The following is a description of a gene set: studied in species Mus musculus Genes up-regulated after 10 h of TGFB1 stimulation in MEF cells (embryonic fibroblast) with NFIC knockout vs wild type MEFs. Human Gene Set: PLASARI_TGFB1_SIGNALING_VIA_NFIC_10HR_UP Transforming growth factor beta (TGF-beta) and platelet-derived growth factor A (PDGFAlpha) play a central role in tissue morphogenesis and repair, but their interplay remain poorly understood. The nuclear factor I C (NFI-C) transcription factor has been implicated in TGF-beta signaling, extracellular matrix deposition, and skin appendage pathologies, but a potential role in skin morphogenesis or healing had not been assessed. To evaluate this possibility, we performed a global gene expression analysis in NFI-C(-/-) and wild-type embryonic primary murine fibroblasts. This indicated that NFI-C acts mostly to repress gene expression in response to TGF-beta1. Misregulated genes were prominently overrepresented by regulators of connective tissue inflammation and repair. In vivo skin healing revealed a faster inflammatory stage and wound closure in NFI-C(-/-) mice. Expression of PDGFA and PDGF-receptor alpha were increased in wounds of NFI-C(-/-) mice, explaining the early recruitment of macrophages and fibroblasts. Differentiation of fibroblasts to contractile myofibroblasts was also elevated, providing a rationale for faster wound closure. Taken together with the role of TGF-beta in myofibroblast differentiation, our results imply a central role of NFI-C in the interplay of the two signaling pathways and in regulation of the progression of tissue regeneration. from publication Plasari G, Calabrese A, Dusserre Y, Gronostajski RM, McNair A, Michalik L, Mermod N (PMID 19752192), and this is the list of marker genes: PARM1, PIERCE1, RICTOR, CLCA3P, IL18RAP, EPHA7, RGS5, STEAP2, SPARCL1, COL2A1 (collagen type II alpha 1 chain), NRN1, MYH11, C1S, ITGA1, NFIB, FAS, CHODL, STK26, PERP, XRN1, PCSK5, AIF1L, PDK4, RGS4, ADGRG6, PLSCR1, EPHA4, NREP, SEMA3C, CSF1, CPXM1, GJB4, IRAG1, PLEKHH2, VCAM1, CELSR3, UNC5C, IL1RAP, IFI44, CYP2J2, CD38, F3, NNAT, ANO1, ARC, TBX3, FGF7, GVINP1, ORAI2, GPM6B, ENPP5, PAX1, OLR1, SLMAP, KDM5A, TMTC4, MPZL2, SERPINA3